Given this list of marker genes BAZ1B, NCAPD3, NCAPG2, SMARCA5, NCAPD2, SMC2, NCAPG, SMC4, CCNB1, NCAPH, H3-3A, NCAPH2, H3-3B, MCPH1, here is a description of the gene set: studied in species Homo sapiens Human Gene Set: GOBP_REGULATION_OF_CHROMOSOME_CONDENSATION Any process that modulates the rate, frequency, or extent of chromosome condensation, the progressive compaction of dispersed interphase chromatin into threadlike chromosomes prior to mitotic or meiotic nuclear division, or during apoptosis, in eukaryotic cells.